The following is a description of a gene set: Reactome Pathway: Post-chaperonin tubulin folding pathway Alpha and beta tubulin folding intermediates are formed through ATP-dependent interaction with TriC/CCT. In order to form a functional heterodimer, these folding intermediates undergo a series of interactions with five proteins: (cofactors A-E) following release from TriC/CCT. These interactions are described in the reactions below. Ultimately, alpha tubulin, when associated with cofactor E, interacts with cofactor D-bound beta-tubulin. The entry of cofactor C into this complex results in the discharge of native heterodimer triggered by GTP hydrolysis in beta tubulin. part of: Protein folding studied in species Homo sapiens, and this is the list of marker genes: TUBA4A, TUBB6, TBCA, TUBA3E, TBCE, TBCC, TBCB, TUBA1A, TUBB2B, TUBA3C, TUBAL3, TUBB4A, TUBA3D, TUBB4B, ARL2, TUBB2A, TBCD, TUBB3, TUBA1C, TUBA1B (NCBI Gene Id 88851), TUBA8, TUBB1, TUBA4B